Given this list of marker genes BAIAP2L1, TMEM38B (transmembrane protein 38B), MGLL, CRAMP1, TRIAP1, WNT3A, MFAP3, DNAAF4, GKN2, TM7SF2, RPP25L, TNFAIP8L1, PURG, PDGFC, MNT (MAX network transcriptional repressor), LSM10, LYPLAL1, CYP7B1, DLG2, PRKD2, MAP2, APOM, NPAS1, ST6GALNAC1, ACTN2, GPR84, RPRD1A, EBPL, JARID2, ZNF474, SNRNP25, HSPB8, PLOD3, ASCC1, TUBB4A, MMP15, CXCR4, LRRC8A, SLC30A1, PPIF, FANCE, DNAJB13, CRISP3, UNC13A, FAM184B, SDC4, DRG2, ESRRG, CORO2B, LGALS2, SPI1, LSM14A, NOP16, RFC2, ATF7, CSF1, MMAB, KPNA6, OARD1, RGS5, MAGEL2, INO80E, SUPT4H1, FKBPL, ILKAP, CXCL17, PROSER2, NKAPL, PHF13, QTRT1, ING4, PTPRCAP, C1orf131, BRD4, ID3, TMEM191C, ADGRA2, CEP112, CILP2, SNHG11, TRIM13, KLHL21, COL17A1, CKAP2, LBX2 (NCBI Gene Id 85474), RNF41, POMGNT1, GTF3C5, GNAT1, SLC4A8, STRA6, PTPRG, PTOV1, RNF167, IER5L, MAGEH1, PRKCZ, PSMC5, GIPC3, RTKN, CHDH, CYTH2, ECI1, DDIT3, OSGEP, CCDC92, PAX8, EPHA4, MYL6B, EDNRB, TCEAL9, AXIN1, SRR, TULP2, UBIAD1, PPP1R17, TMCO4, GPR85 (NCBI Gene Id 54329), ATOX1, EPYC, RGS20, RASL11B, GUCA1B (guanylate cyclase activator 1B), UBE2F, PLAT, AAMDC, CNNM4, AZGP1, SFTPC, CBX2, CLDN18, GRIN2C, SPAG1, CACNA1G, USP21, DGAT2, TTYH2, CTTN, TEX13B, BEX3, HYAL3, SYN2, TTC23, HLF, ADARB2, BCAP31, SPRR3, PHLDA2, RRAS, GSAP (gamma-secretase activating protein), G0S2, TINF2, GSDMA, ANXA5, PLCB3, CYP2F1, SLC22A17, ENPP2, POP5, GRHPR, C6, WNT10B, S1PR4, KRT23, AP2A1, MRPL57, NRARP, HTR2C, ARMCX4, TBXA2R (NCBI Gene Id 6915), ZNF48, ZIC2, RBM38, STAP2 (signal transducing adaptor family member 2), DMBT1 (NCBI Gene Id 55583), CPLX2, TOMM6, SRXN1, NPPC, FAM110A, FAM222B, AFM, BYSL, PIP5K1C, EPB41L5 (erythrocyte membrane protein band 4.1 like 5), CFAP68, IL20, GTF2E2, LARP7, OSGIN1, CMC2, TBX1, UGT3A2, TNFSF9, SNTB1, NFIB, CCDC115, ZBTB2, ARMC7, here is a description of the gene set: Thymic-derived natural T regulatory cells (nTregs) are characterized by functional and phenotypic heterogeneity. Recently, a small fraction of peripheral Tregs have been shown to express Klrg1, but it remains unclear the extent Klrg1 defines a unique Treg subset. Here we show that Klrg1+ Tregs represent a terminally differentiated Treg subset derived from Klrg1- Tregs. This subset is a recent antigen-responsive and a highly activated short-lived Treg population that expresses enhanced levels of Treg suppressive molecules and that preferentially resides within mucosal tissues. The development of Klrg1+ Tregs also requires extensive IL-2R signaling. This activity represents a distinct function for IL-2, independent from its contribution to Treg homeostasis and competitive fitness. These and other properties are analogous to terminally differentiated short-lived CD8+ T effector cells. Our findings suggest that an important pathway driving antigen-activated conventional T lymphocytes also operates for Tregs. Gene expression analysis was performed of this and other Treg subsets based on expression of CD62L, CD69, and Klrg1 to define the molecular properties of Klrg1+ Tregs and its relationship to other Treg subsets found in the peripheral immune tissues. from publication Cheng G, Yuan X, Tsai MS, Podack ER, Yu A, Malek TR (PMID 22786769) species: Homo sapiens Genes down-regulated in CD69- KRLG1- T reg: SELL high versus SELL low. Human Gene Set: GSE36527_CD62L_HIGH_VS_CD62L_LOW_TREG_CD69_NEG_KLRG1_NEG_DN